The following is a description of a gene set: Human Gene Set: GOBP_CALCIUM_MEDIATED_SIGNALING Any intracellular signal transduction in which the signal is passed on within the cell via calcium ions. species: Homo sapiens, and this is the list of marker genes: SLC8A2, PTPRC, SELE, PPP3CC, ATP2A2, KCNJ8, CCR5, PDK2, GRIK3, AGTR1, CA8, RYR3, TPRG1L, GSTO1 (NCBI Gene Id 9446), NFATC2, CLEC7A, MIR133A1, CALM2 (NCBI Gene Id 805), REM1, CD3E, NR5A2, SELENOK, ORAI1, MCU, EFHB, P2RX1, CX3CR1 (NCBI Gene Id 2836), CMKLR1, TRPM4, RAMP3, HTT (NCBI Gene Id 3064), TMEM100, TREML1, P2RX5, MIR1-1, NCALD, TPCN2, TPCN1, GRIN1, JPH3, CHP2, PDGFRA, PRNP, HPCA, ACKR2 (NCBI Gene Id 95073), CCR8, CCR4, SPPL3 (signal peptide peptidase like 3), CDH13, MYOZ1, TBC1D10C (TBC1 domain family member 10C), TRPA1, FPR2, PLN, PRKD1, C10orf71, CCL3, CAMK2D, GSTM2, ITPR2, TRDN, CHP1, CAMTA1, INPP5A, LAT2, SLA2, EDN1, RYR2, NFATC1, P2RY11, SAMD14, MYOZ2, NUDT4, CLIC2, LAT, CCRL2, CASQ1, PKD2, GRIN2D, LRRK2, MCOLN3, APP (NCBI Gene Id 351), MCOLN1, SPHK1, MAPT, FKBP1A, DEFB1, CCL20, PPP3CB, CCL4 (C-C motif chemokine ligand 4), P2RX4, RCAN1 (regulator of calcineurin 1), BNIP1, RCAN3, PLCG2, JPH2, PLEK, NEUROD2, ACTN3, GNA15, NFATC4, ZAP70, IAPP, EIF2AK3, CXCR3, TREM2, MTOR, CXCR6, PLCG1, CCR6, PCP4, NFATC3, PPP3R2, CCR1, CXCR4, ACKR3, NMUR1 (neuromedin U receptor 1), TMBIM4, TRPM2, TRPM8, RGN, CXCR1, HOMER2, DMD, BST1, XCR1, NEGR1, ATP1A2, SLC8A1, NR5A1, SLC9A1, CHERP, HINT1, PTBP1, NMUR2, CCR3, CCR2, JPT2, FHL2, CHRM3, PPP1R9B, CCR9, CCR7, P2RX7, HRC, EDNRB, TRPV1, CAMKK2, MCTP2, ADA, RCAN2, ASPH, IGF1, BHLHA15, SLC24A4, AKAP5, CASQ2, AKAP6 (NCBI Gene Id 9472), GRIK1, P2RY12, GRIA1, OPRL1, FKBP1B, EDN2, KSR2, GRIN2B, JPH4, P2RX2, NOS1, GBP1, PTPRJ, TMEM38B, PRKACA, ANK2, ITPR1, NFAM1, CALM1, ACKR4, RIT2, LMCD1, PLCE1, TMEM38A, GPRC6A, MCOLN2, NFAT5, TNNI3, GRIK2, GRIN2A, HTR2C, TNF, CD4, LACRT, ATP2B4, SGCD, CD22, CXCR2, CALM3, ADGRB2, PPP3CA, ITPR3, GRIA3, PDGFRB, GPR62, AVPR1A, HTR2B, P2RX3, FCGR3A, CCR10, ZMPSTE24, MAPK7, SYK, C3AR1, CALCR, PTGDR2, POMC, PPP1R9A, MYH7B, TNFSF11, DMPK, JPH1 (junctophilin 1), RYR1, KCNJ11, GRM5, DYRK2, GSK3B, PPP3R1, CXCL8, PRKAA1, PDPK1, BTK, MCTP1 (NCBI Gene Id 79772), IRGM, HOMER3, PLA2G4B (phospholipase A2 group IVB), ERBB3, CXCR5, CACNA1C (calcium voltage-gated channel subunit alpha1 C), CIB1, ATP1B1, TRAT1